The following is a description of a gene set: Any process that modulates the frequency, rate or extent of amyloid-beta clearance. Human Gene Set: GOBP_REGULATION_OF_AMYLOID_BETA_CLEARANCE studied in species Homo sapiens, and this is the list of marker genes: LRPAP1, LRP1, MYOCD, MIR34A (microRNA 34a), SRF, IFNG, CLU, ABCA7, CYP51A1, TREM2, TNF, PLA2G3, MIR1908, IFNGR1, APP, HMGCR, SREBF2, ROCK1, IL4, TTPA, APOE